Given this list of marker genes Tirap, Tcf3, Ikzf3, Vpreb1a, Card11, Cdkn2a, Vpreb1b, Ighe, Tfrc, Pten, Rasgrp1, Muc19, Il7r, Pkn1, Tnfrsf4, Prkcd, Abl1, Casp3, Ahr, Fosl2, Lef1 (lymphoid enhancer binding factor 1), Chrnb2, Il5, Cd22, Ighd, Gapt, Ephb2, Prlr, Il10, Bcl6, Il4, Btla, Nfatc2, Bst1, Bmi1, Tlr4, Tnfsf13b, Nfkbiz, Ctla4, Peli1, Cd74 (CD74 antigen (invariant polypeptide of major histocompatibility complex, class II antigen-associated)), Ada, Tyrobp, Sash3, Cd320 (CD320 antigen), Cd27, Cd70, Mef2c, Shb, Il3, Tnfrsf13c, Cr2, Il13 (NCBI Gene Id 16163), Il7, Cfb, Vav3, Nckap1l (NCK associated protein 1 like), Cd180 (NCBI Gene Id 268699), Cd40lg, Ighm, Plcl2, Il9, Pawr, Lyn, Mzb1, Rc3h1, Cd24a, Cd300a, Bax, Il9r (interleukin 9 receptor), Cdkn1a, Cd40, Il21, Wnt3a, Cd81, Clcf1, Btk, Atad5, Mif, Ptprc, Cd19, Slc39a10, Irs2, Atm, Pcyt1a, Ticam1, Inpp5d, Tnfsf13, Hspd1, Tnfrsf21, Fcgr2b, Ifnb1, Bcl2, Tnfrsf13b, Il2 (interleukin 2), Ctps1, Tsc2, Tlr9, Cd79a, Gpr183, Siglecg, Cd38, Rag2, here is a description of the gene set: The expansion of a B cell population by cell division. Follows B cell activation. Mouse Gene Set: GOBP_B_CELL_PROLIFERATION studied in species Mus musculus